The following is a description of a gene set: studied in species Mus musculus Mouse Gene Set: GOBP_ADHESION_OF_SYMBIONT_TO_HOST The attachment of a symbiont to its host via either adhesion molecules, general stickiness, or other mechanisms. The host is defined as the larger of the organisms involved in a symbiotic interaction., and this is the list of marker genes: Nectin2, Bpifa5, Scarb1, Gas6, Ace2, Gbp2, Gbp2b, Icam1, Hsp90ab1, Gbp9 (guanylate-binding protein 9), Gbp7, Hspd1, Bpifa1, Lrrc15, Ltf, Gbp6 (guanylate binding protein 6), Gbp3